The following is a description of a gene set: Human Gene Set: RICKMAN_METASTASIS_DN Genes down-regulated in metastatic vs non-metastatic HNSCC (head and neck squamous cell carcinoma) samples. studied in species Homo sapiens Propensity for subsequent distant metastasis in head and neck squamous-cell carcinoma (HNSCC) was analysed using 186 primary tumours from patients initially treated by surgery that developed (M) or did not develop (NM) metastases as the first recurrent event. Transcriptome (Affymetrix HGU133_Plus2, QRT-PCR) and array-comparative genomic hybridization data were collected. Non-supervised hierarchical clustering based on Affymetrix data distinguished tumours differing in pathological differentiation, and identified associated functional changes. Propensity for metastasis was not associated with these subgroups. Using QRT-PCR data we identified a four-gene model (PSMD10, HSD17B12, FLOT2 and KRT17) that predicts M/NM status with 77% success in a separate 79-sample validation group of HNSCC samples. This prediction is independent of clinical criteria (age, lymph node status, stage, differentiation and localization). The most significantly altered transcripts in M versus NM were significantly associated to metastasis-related functions, including adhesion, mobility and cell survival. Several genomic modifications were significantly associated with M/NM status (most notably gains at 4q11-22 and Xq12-28; losses at 11q14-24 and 17q11 losses) and partly linked to transcription modifications. This work yields a basis for the development of prognostic molecular signatures, markers and therapeutic targets for HNSCC metastasis. from publication Rickman DS, Millon R, De Reynies A, Thomas E, Wasylyk C, Muller D, Abecassis J, Wasylyk B (PMID 18679425), and this is the list of marker genes: CENPT, CAMK2D, C1orf162, ZDHHC12, NHSL3, AP3D1, PRODH, HRAS, RNF126, FZR1 (fizzy and cell division cycle 20 related 1), CLK3, MIR210, MTUS1, PTAFR, CCM2, EHBP1L1, TMEM259, NMRK1, S100A11, TAGLN2, MPDU1, RHOG (NCBI Gene Id 391), IRF6, ADAMTSL4, TRAFD1, MAPK11, PHLDA3, SPRYD7, GJB3, LAD1, STXBP2, KRT17, FLJ40288, TSPAN14, DSC3, TUFT1, MEGF11, ATP2B4, SPI1, PERP, CD177, PTK2B, SLC2A1, PSD4 (pleckstrin and Sec7 domain containing 4), TAP1, ZBTB7B, S100A2, CASP1, RHOV, NPM2, DAPK3, ABHD17A, GAS2L1, CAMKK2, BICD2, RDX, C15orf39, MIR205HG, ATP6V1B2, MAPK12 (NCBI Gene Id 6300), POLR2E, PPP2R1B, FXYD3, IL18BP (NCBI Gene Id 10068), MRPL4, LMF2, DOK2 (NCBI Gene Id 9046), ARF1, ADCY7, MYCL, BAIAP2, ACTBP9, ACTR3, TBC1D2, KCNK1, RBM34, MALL, GTPBP1, RNF19B, NDUFA4L2, CD58, VASP, KEAP1, PSMB9, IGSF3, COX6B2, ST6GALNAC4, BCL2L1, GUK1, TYMP, TPM4, SFN, RASSF5, LY6D, FLYWCH1, HELZ2, PAX8, A4GALT, DENND1A, PKP3, SLC19A1 (NCBI Gene Id 6573), PTGS2, GFOD1, RALGDS, GET3, SGMS1, ZMAT5, MMP28, PCSK7, ANXA2P3, DUSP7, NUAK2, POTEKP, FAM53B, TNFSF9, PTGIR (prostaglandin I2 receptor), TOM1L2, TAP2, DMTN, MEF2D, SECTM1, BSG, TBC1D10A, IFITM1 (interferon induced transmembrane protein 1), SCAMP2, RGS14 (NCBI Gene Id 10636), PKP1, PRF1, HSD17B1, DDA1, CFAP251, TSPO, RHOA, MOB3A, AGAP3, KRT6A, IL18, AHNAK2, NAA80, NLRC5, PGAM1, SGPL1, CDCP1, SNX33, ALS2CL, ABCB9, SCO2, SLC6A8 (solute carrier family 6 member 8), MAP2K2, CARM1, GNA15, GIPC1, HK1, GBP1, NLRP1, SH3GLB2, LRRC8A, ANXA8, JPT1, JUP, IFI16, MKNK2, PITPNM3, ENDOG, AMPD3, CKMT1B, SEMA3F, S1PR5, CAP1, NECTIN1, SDC1, CAPG, SLAMF8, ALDH16A1, SPRR1B, MIER2, CORO1C, DNM2, SH3BGRL3, MUC1, LMNA, MYO1E (myosin IE), RNH1, RHOF, STARD10, SPATA24, MIR205, OGDH, ATP5F1D, ZBTB7A, ADAM15, PALMD (NCBI Gene Id 93975), CD44, TNFAIP8, ZNF750, RAB7B, ATG4D, UBAP2L, SH3GL1, TXN, ARHGEF12, TFEB, NECTIN4, EPPK1, DST, MAPKAPK2, MAP2K7, FARSA, STPG1, CACTIN, OSTF1, TRIM29, TNPO2, CD209, FCER1G, GBP2, MYO1G, MORC3, KLHDC7B-DT, FOSL2, TRAPPC1, S100A6, R3HDM4, ZAP70, SLC27A3, S100A14, TIRAP, PDLIM1, BAK1, NDRG1, MPZL2, ITGB4, DSG3, GNLY, KRT5, RXRA, ENSG00000291149, LCP2, RPS6KA4, THOP1, S100A16, PML, PKM, HES7, SLC16A3, CD300LF, PAFAH1B2, CDKN1A, NAV1, PRRG4 (proline rich and Gla domain 4), TBC1D22A, AVPI1, DOCK8, TRIR, MYD88, BTBD2, ARPC5, PROM2, AKIRIN2, FLOT2, KLF13, BAP1